The following is a description of a gene set: Mouse Gene Set: GOBP_MAINTENANCE_OF_PROTEIN_LOCATION studied in species Mus musculus Any process in which a protein is maintained in a location and prevented from moving elsewhere. These include sequestration, stabilization to prevent transport elsewhere and the active retrieval of proteins that do move away., and this is the list of marker genes: Fam76b, Taf3, Mdfi, Sufu, Kdelr2, Fkrp, Txn1, Kdelr3, Pgr, Topors, Insig1, Cer1, Hk1, Bard1, Morc3, Tnrc6a, Srgn, Grk2, Akt1, Pink1, Cd4, Cav1, Taf8, Pml, Hk2, Tmed2, Lgals3, Vps13c (NCBI Gene Id 97581), Gja1, Nbl1, Chrd (NCBI Gene Id 12667), Dand5, Vps13a (vacuolar protein sorting 13A), Syne1, Sp100, Vps13d, Hdac3, Grik5 (glutamate receptor, ionotropic, kainate 5 (gamma 2)), Lgals1, Sun1, Ankrd13c, Nrros, Dbn1, Nr5a1, Hnrnpu, Adcy6, Sun2, Igsf11, Pkp2, Skp1, Arl2bp, Cdk5, Fbn2, Tspo, Supt7l, Park7, Ltbp1, Mprip, Pex5l, Bbs4, Frey1, Kdelr1, Lgals9, Fbn1, Sppl2c, Rer1, Os9, Arl2, E230001N04Rik, Rangap1, Ciz1, Sorl1, Insig2, Ank3, Rit2, Hspa5, Golph3, Ccdc88a